Given this list of marker genes MAST1, SHMT2, SLC52A3, FGF14, EIF2AK2, GRID2, SLC30A10, PIGA, SYT14, ATG5, NKX6-2, ATP8A2, BCL11A, PRNP, GBA2, CERS1, SLC1A3, OPA1, POLR3A, ATXN3, POLR1A, ATP1A3, TTBK2 (NCBI Gene Id 26044), CYP7B1, KCTD7, EBF3, TTR (transthyretin), HARS1, CEP120, COX6B1, MSTO1, WDR81, VLDLR, KCND3, CWF19L1, MECP2, ATCAY, ATP2B3, SLC9A6, APTX, VPS13D, POLG, ABCD1, SLC25A15, EEF2, DAB1, MT-TN, ANO10, SURF1, NOP56, CACNA1A (NCBI Gene Id 773), RNU12, VWA3B, STUB1, DARS2, UROC1 (NCBI Gene Id 131669), PPP1R15B, NDUFA13, TRAPPC11, TPK1, COG5, SPTBN2, NAT8L, SACS, ADGRG1, CACNB4, AP2M1, ATXN1, LRPPRC, VPS41, DOHH, ITPR1, SDHA, PEX10, ATN1, HIBCH, here is a description of the gene set: Human Gene Set: HP_TRUNCAL_ATAXIA Truncal ataxia studied in species Homo sapiens Truncal ataxia is a sign of ataxia characterized by instability of the trunk. It usually occurs during sitting.